Given this list of marker genes Mir467a-9 (NCBI Gene Id 100526554), Snrpa1, Mir324, Gsk3b, Snw1, Gm6525, Mrpl30, Rplp1, Mirlet7d, Eif2s1, Larp7, U2af1, Nol10, Alyreffm6, Eif3j1, Nvl (nuclear VCP-like), Mrpl4, Gar1, Srp72, Rpl26, Mrpl10, Eif2c5l (NCBI Gene Id 286951), Emg1, Rpl4, Ppil1, Nip7, Nhp2, Mrpl9, Alyreffm7, Snrnp48, Ddx4, Mir467a-6, Riok3, Ppie, Nop10, Htatsf1, Aatf, Rpl13-ps6, Mir222, Mrps25, Rps19, Csnk1a1, Rpl36al, Dyrk2, Tarbp2, Nop9, Rbmyf9, Rps25, Prpf3, Tert, Rbms1, Nufip1, Rrp15, Celf6, Rps18-ps6, Mir20a, Sf3b2, Arfgef1, Yju2, Dicer1, Rpl10, Srp54a, Mrpl34, Mir221, Mir362, Gnl3l, Mrpl20, Mir26a-2, Prpf6, Mir219a-2, Ddx1, Nop14, Fbl, Rpl10a, Patl2, Pabpc4l, Mrpl11, Rpl35a, Mir466h, Dimt1, mt-Rnr1, Dkc1, Mir451b, Zfp36l1, mt-Rnr2, Mir500, Eif2d, Mrpl32, Mir467a-2, Rnf113a1, Dhx9, Pdcd7, Hnrnpa1, Rbmxl1, Pno1, Rack1, Snrnp25, Rpf1, Eif1, Mir28a, Pa2g4, Rps2, Hexim1, Nsun4, Rbms2, Syf2, Srrm2, Lsm10, Top2b, Snip1, Mterf4, Rpl37a, Rrp1, Rrp9, Eif4e, Rps27rt, Mir26b, Rpl37rt, Adar, Ncl, Apobec3, Mir34c, Mirlet7b, Tdrd6, Prpf4b, Rpp14, Dhx29, Eftud2 (NCBI Gene Id 20624), Rnf135, Akap8l, Cwc15, Ybx2, Tial1, Usp39, Mrps31, Sart1, Utp18, Bop1, Mrpl37, Cdc5lrt1, Mir124a-2 (NCBI Gene Id 723950), Rps3a1 (NCBI Gene Id 20091), Stau1, Mir486, Isy1, Eef2, Xpo1 (NCBI Gene Id 103573), Riok2, Imp3, Rps15a, Alyreffm11, Snrpg, Pes1, Rpp21, Cript, Rps27a, Mrps26, Rps23, Mrps28, Rps6kl1, Rpl9-ps1, Rpl32, Rps7, Mir467a-8, Eif3k, Sf1, Ppihl, Dhx8, Mir1a-2, Dap3, Eif4a3, Mrps12, Mpv17l2, Mrps9, Sf3a2, Erg, Mir744, Hnrnpm, Prkdc, Hnrnph3, Celf4, Exosc10, Wdr74, Pop4, Npm1, Mir5100, Cwf19l2, Rps10, Snora64, Rpl41, Rbm8a, Cwc25, Srek1, Fmr1, Ilf3, Mrpl52, Ins2, Phax, Cactin, Noc4l, Myo5a, Mir320, Rps20, Znhit3, Khdc4 (NCBI Gene Id 99643), Rpl18a, Ddx17, Wdr43, Cdc5lrt4, Mir139, Txnl4a, Ftsj3, Alyreffm8, Dhx37 (NCBI Gene Id 381671), Ess2, Gapdhrt, Ppih, Lsm4, Pwp2, Upf1, Ago4, Mrps18a (NCBI Gene Id 98069), Ago3 (argonaute RISC catalytic subunit 3), Rpl21, Rbmyf3, Wbp4, Dqx1, Cdc5lrt10, Utp14b, Nol7, Mir5128, Mir101a, Zfp830, Eif3c, Ybx1, Ptges3, Cdc5lrt8, Gpatch1, Pabpn1, Srp14, Rpl3, Ruvbl1, Lsm7, Api5, Mir21a, Mir140, Mak16, Mir16-1, Snora68, Ppp1r8, Bms1, Rpl13, Rpl18, Snrpe, Limd1, Hnrnpk, Nsrp1, Mir30c-1, Mrpl16, Celf2, Nob1, Utp11, Mir124a-3, Rps27l, Eif3h, Zfp622, Igf2bp1, Rrp1b, Eif3b, Larp4, Zmat5, Eif3d, Rbm12b1 (RNA binding motif protein 12 B1), Nron, Noc2l, Mrps35, Cwc22rt2, Snrpb2, Acd, Cbx5, Rbmx, L1td1, Iqgap1, Prpf19, Rpl36, Xab2, Rpl32l, Zc3h14, Mrpl39, Mir466d, Nup50, Txnl4b, Rps15, Nol6, Rbm42, Wdr83, Chchd1, Rps17, Rpl34, Hnrnpl, Gadd45gip1, Mir467a-3, Cwc27, Rps28, Utp15, Mrps7, Luc7l3, Mir326, Snrpn, Mir361, Prpf38a, Mir19b-1, Magohb, Nup98, Snrpb, Tra2a, Rpl5, Mrpl24, Utp4, Mir16-2, Mir30c-2, Mrpl36, Alyref2 (Aly/REF export factor 2), Prkra, Pabpc4, Nsa2, Rpl10-ps3, Tep1, Pcbp2, Rrp36, Dhx16, Prpf39, Mrpl51, Eif3a, Nsun3, Rplp1rt (ribosomal protein lateral stalk subunit P1, retrotransposed), Rps16, Hnrnpa0, Pih1d1, Tfip11, Gemin2, Hnrnpul1, Zfp36l2, Rps18, Fbll1, Mir467a-1, Brca1, Mir20b, Rps19bp1, Prpf38b, Akap17b, Mir708, Cwf19l1, Hnrnpu, Rheb, Secisbp2l, Mrps10, Rpl19, Cwc22rt7, Hnrnpf, Rpl7l1, Sf3b6, Rpl10l, Zfp36, Snora69, Mir652, Mfap1b, Rps6-ps4, Parp4 (NCBI Gene Id 77419), Mir505, Snrnp40, Dhx38, Mrpl41, Casp8, Plrg1, Mir342, Frg1, Rpl32-ps, Mirlet7i, Aqp7, Rpl7, Mrpl44, Mir23a, Rpl39, Rpl35rt, Elavl1, Rps21, Mrpl21, Snu13, Alyreffm10, Mrps21, Rps9, Gpkow, Cpsf6, Mir106a, Pih1d2, Mir467a-7, Rpl27rt, Ptbp2, Srsf2, Rpl38, Tia1, Mrps34, Mir345, Hnrnpab, Kri1, Ppil2, Dcp2, Sf3b5, Wac, Mrps22, Rpl27a, Ssb, Rpl29 (ribosomal protein L29), Cpsf3, Rps13, Actn4, Snrnp35, Srp54b, Mir124a-1, Hnrnpc, Pop5, Lsm8, Pin4, Rps4l, Utp20, Rrs1, Rbm28, Eif3f, Pcbp3, Smndc1, Snrnp200, Utp23, Cdc5lrt7, Grsf1, Rps5, Rbm17, Mrpl49, Lsm1, Prpf4, Mir532, Mrpl28, Sf3b4, Mphosph10, BC005624, Mir29a, Hspa1a, Slu7, Sf3b3, Srp68, Slx9, Efl1, Eif3g, Jakmip1, Rpl35, Rps11, Dhx35, Sf3b1, Magoh, Rpl13a, Nat10, Mirlet7c-1, Mrpl22, Hsd17b10, Mirlet7c-2, Lsm6 (NCBI Gene Id 78651), Ctnnbl1, Smg5, Ddx23, Rbm41, Snrpd1, Rnpc3, Rplp0, Pabpc1l, Gm7324, Snora70, Sra1, Mir30a, Mir101b, Hsf1, Dyrk1a, Rpl23a, Mirlet7a-2, Hnrnpa3, Casc3, Mrpl50, Lncbate1, Mir1981, Eefsec, Utp3 (UTP3 small subunit processome component), Jmjd6, Rps3, Rpl24, Pnn, Prkrip1, Rpl7a, Mir374b, Eif1b, Srp19, Wdr12, Mrpl3, Ttf2, Taf9, Utp25, Alyreffm4, Tnrc6a, Rplp2-ps1, Rpp38, Pcbp1, Phf5a, Prpf8 (pre-mRNA processing factor 8), Ddx6, Mir7-1, Cdc5lrt5, Ngdn, Mrps14, Mrps30, Alyreffm9, Rpl37, Cirbp, Sf3a1, Mrps33, Xpo5, Tra2b, Ddx3x, Hspa8, Prorp, Snrpa (small nuclear ribonucleoprotein polypeptide A), Slbp, Wdr46, Mir19b-2, Srrm1, Gapdh-ps15, Mrps16, Mir150, Armc7, Hspa1b, Aar2, Snrnp27, Trim21, Rbm8a2, Zmat2, Mrpl2, Snora65, Wrap53, Mir145a, Mirlet7g, Mrps11, Mrpl27, Rps8, Rpl6, Mepce, Mirlet7a-1, Rbm48, Eif2a, Pdcd11, Mir1839, Srrt, Ccdc12, Mrpl35, Uba52, Mrpl23, Snrpd3, Rpl34-ps2, Snrpd2, Mir26a-1, Mir669o, Mir467e, Mrpl14, Mir194-2, Ptcd3, Prpf31, Uba52-ps, Eri1, Mrpl58, Rpl11, Rps6, Tssc4, Alyreffm3, Gapdhrt2, Mir5106, Mir106b, Lsm11, Riok1, Slirp, Suz12, Jrk, Rplp2, Uba52rt, Rpl36a, Snrpert, Mir194-1, Eif4a3l1, Rpl28, Mrps17, Mrpl55, Cwc22rt5, Mir3068 (microRNA 3068), Aurkaip1, Rbm12b2 (NCBI Gene Id 77604), Ppan, Mir298, Tefm, Rpl9, Mtrex, Lrrk2 (NCBI Gene Id 79409), Cwc22rt6, Pop7, Bud13, Nfatc2, Elavl3, Zcchc17, Cwc22, Rbmy, Rpl39l, Mir27a, Rbm3 (RNA binding motif (RNP1, RRM) protein 3), Mirlet7f-1, Mrps24, Ppwd1, 2810004N23Rik, Crnkl1, Eprs1, Scnm1, Mir122, Mir17 (NCBI Gene Id 723905), Snrnp70, Rcl1, Larp7-ps, Ebna1bp2, Mrps18b, Mdn1, Mir3473b, Mrpl45, Rbmxl2, Mrpl15, Mir322 (microRNA 322), Snrpf, Mir350, Rpl23, Rpl34-ps1, Ddx41, Srp54c, Nop58, Zcchc8, Eif1a, Mfap1a, Lgals3, Rbm44, Eif3i, Mrpl42, Rnf113a2, Mir466g, Pabpc5, Ruvbl2, Larp6, Alyreffm5, Cd2bp2, Tdrd1, Rpl14 (ribosomal protein L14), Mir467a-10, Rpl22l1, Rbm22, Celf1, Hnrnph2, Rpl17, Mrpl47, Myef2, Rbmx2, Yju2b, Bcas2, Rpl8, Mrpl13, Trp53cor1, Rps4x, Rpl9-ps6, Atxn2, Tbl3, Cdc5l, Zcrb1, Rpl12, Mrps5, Ddx46, Cwc22rt4, Hnrnpd, Nup62, Lsm5, Rpl6l, Mrpl18, D1Pas1, Rpsa, Rpl27, Wdr3, Mrpl43, Clns1a, Mir3968, Cpeb1, Mir466m, Rbm12, Tunar, Zrsr2, Lsm14a, Mrpl19, Mrps18c, Lsm2, Cdc40, Mir15b, Rpl3l, Nop56, Rbms3, Rpl15, Utp14a, Zc3h18, Fau, Mir669f, Rpl22, Alyreffm1, Mrpl38, Gcfc2, Dazap1 (DAZ associated protein 1), Pcbp4, Hnrnpa2b1, Znhit6, Puf60, Mrps2, Mrpl33, Zfp827, Sugp1, Ppil3, Rps26, Esrp2 (NCBI Gene Id 77411), Mir219a-1, Tdrd7, Rpl36-ps12, Xrcc5, Prpf40a, Bysl, Sf3a3, Eif3j2, Mir467a-5, Rps27, Dcaf13, Rpp40, Mir181c, Ddx42, Snora62, Alyref, Cwc22rt3, Mrpl46, Ago2, Mirlet7f-2, Rps14, Rbmyf1 (RNA binding motif protein Y-linked family member 1), Eif1ax, Nolc1, Smg7, Lsm3, Mir451a, Mir331, Ptges3-ps, Srp9, Mcts1, Wdr75, Ighmbp2, Mrps23, Elavl4, Ddx5, Gm6133, Csnk1e, Dhx15, Mrpl54 (NCBI Gene Id 66047), U2af2, Celf3, Mir1a-1, Rbmyf6, Mrps6, Ilf2, Ncbp1, Cdc5lrt9, Prpf18, Ro60, Mrpl17, Dnttip2, Rps24, Eif3l, Esrp1, Smu1, Pabpc2, Dhx32, Pabpc6, Mir338, Imp4, Wdr36, Mrpl57, Cdc5lrt6, Rps12, Snrpc, Hnrnpr, Elavl2, Lsm14b, Mir374c, Ddx39b, Sart3, Tex16, Naf1, Rpp25, Rpl30, Celf5, Mrps15, Rbm5, Mir195a, Mir144, Aqr, Snd1, Mrpl1, Mrpl12, Mir5099, Heatr1, Pop1, Rrp7a, Raly, Secisbp2, Rpl17-ps8, U2af1l4, Fcf1, Riox1, Mir328, Rps29, Hnrnpll, Ltv1, 9630013A20Rik, Dhx40, Mrps27, Rigi, Ik, Smg6, Gapdh, Eif3e, Syncrip, Bud31 (NCBI Gene Id 97220), Mir455, Prpf40b, Dnajc17, Mrpl53, Rbm45, Ago1, Rpp30, Pabpc1, Hnrnph1, Eif3m (eukaryotic translation initiation factor 3, subunit M), Luc7l, Lrpprc, Srfbp1, Cwc22rt1, Mir669c, Luc7l2, Mrpl40, Eif4a3l2, Mvp, Mir467a-4, Krr1, Rpl31, Rpp25l, Gtf3c1 (general transcription factor III C 1), Top2a, Actb, Mrto4, Mrpl48, Srsf1, Utp6, Trmt10c, here is a description of the gene set: species: Mus musculus Mouse Gene Set: GOCC_RIBONUCLEOPROTEIN_COMPLEX A macromolecular complex that contains both RNA and protein molecules.